The following is a description of a gene set: studied in species Homo sapiens Abnormal CNS myelination Human Gene Set: HP_ABNORMAL_CNS_MYELINATION An abnormality of myelination of nerves in the central nervous system., and this is the list of marker genes: CNOT3, TRNT1, ALG8, NDUFAF4, SDHB, ZNF335, SAMHD1, MMUT, GTF2H5, POLR3B, KDM1A, MPLKIP, IBA57, NDUFS1, YIF1B, TRRAP (NCBI Gene Id 8295), MAT1A, NADK2, ZFX, D2HGDH, PIGO, ACTL6B (NCBI Gene Id 51412), SLC1A4, SUMF1, GFAP, ATP6V1A, POGZ, PGAP1, PPP2R1A, ATP1A3, EXOSC2, LSM11, INTS11, C2CD3, SLC35B2, MTTP, REPS1, DNM1L, UFC1, HCFC1 (NCBI Gene Id 8267), TMTC3, NDUFAF2, COX14, FOXG1, TRAPPC2L, TUFM, GLRX5, ADSL, KIF5A, LIPT1 (NCBI Gene Id 51601), H4C5, ASPA, NDUFV1, ALG2, PLEKHG2, RERE, FBXL4, DOHH, KCNN2, FBXO28, NDUFA6, DHX37, FAR1, PRUNE1 (NCBI Gene Id 91961), IFIH1, AARS1, STXBP1, EPRS1, ITPA, PEX7, DDX6 (DEAD-box helicase 6), TRMT5, GRIK2, WARS1, PIGU, MADD, RNF13 (NCBI Gene Id 11342), ALDH5A1, GET4, PPP1R15B, GEMIN4, COPB2, ALDH7A1, MED17, GLUL, FA2H, TPR, VPS33A, SPTAN1, NDUFS6, ALDH3A2, MED27, ATXN2, CYB5A, CLDN11, MMACHC, IFT56, LRPPRC, ADARB1 (adenosine deaminase RNA specific B1), LEMD2, KIDINS220, CARS1, DAG1, NEUROD2, SMPD4, YRDC, ALG14, FRMD5, ADAT3 (NCBI Gene Id 113179), HS2ST1, BRAT1, SIN3A, FOCAD, LMX1B, KARS1 (NCBI Gene Id 3735), PARS2, TUBB4A, PKDCC (NCBI Gene Id 91461), TNPO2, DDOST, HTRA1, ARF1, TMEM126B, PPP2CA, MLYCD (malonyl-CoA decarboxylase), RNF113A, CTC1 (NCBI Gene Id 80169), FUS, FCSK, PI4KA, GDAP1, PRKDC, ARX, EZH2, ISCA1, PEX16, PGAP3, PEX19, HMBS, RFX7, PHGDH, NUP188, YY1, FANCB, ATP9A, DYRK1A, ZNF148, ZMIZ1, PTEN, SOX10, ZC4H2, U2AF2, RAB11B, AP3D1, FZR1, ESAM, TRMT10A, SLC19A1 (NCBI Gene Id 6573), NKX6-2, SLC1A2, ISCA2, SCO2, PLAA, L2HGDH, SNIP1, RBM8A, TIMM22, KCNH5, ACY1, SLC35A2, GALC, NDUFS8, GOLGA2, TARS1, AHCY, PSAP, SMPD1, PIGS, FUCA1, FOXP1, AIFM1, PPFIBP1, NDUFAF3, RNASEH2A, QARS1, UBA5, FBP2, ACBD5, ALDH6A1, EXOSC1, BCAP31, CYP27A1, CHAMP1, GJC2, PDYN, PEX1, NRCAM, TIAM1, INSR, MCOLN1, ERCC6, NDUFA1, ARSA, TREM2, NARS2 (NCBI Gene Id 79731), SP110, INTU, WDR26, NDUFA11, GNB2, CDC40, NCDN, PPP3CA, SPG11, RNU4-2, COA8, GAA, PGM3, NDUFV2, PGAP2, COG3, GAN, GABRA2, RAB3GAP1, GTF2E2, PEX10, TGFB1, SLC25A12, TBCD, GNAO1, HSD17B4, YME1L1, NDUFS7, RNASET2, ASH1L, ZNF526, SPTLC1, ABCD1, ATP6AP2, EIF2B1, ERCC2, SLC2A1, NEDD4L, TMEM240, NARS1, TKFC, POLR1C, EXOSC5, PIBF1, SHANK3, COX6B1, DHX30, TAF2, ARNT2, TREX1, AFG2A, PLP1, HNRNPC (NCBI Gene Id 3183), CLCN3, RNASEH2B, TBC1D24 (TBC1 domain family member 24), EXOC2, ATP11A, CLCN7, CACNA1I, C2orf69 (NCBI Gene Id 205327), DPAGT1, PHACTR1, HLA-DQB1, NDUFB11, UPB1, MT-ND1, TMEM163, PURA, HSPD1, NDUFB9, DARS2, CDK19, SETD1A, PLPBP, NDUFB3, ADGRG1, ELOVL4, DARS1, MTHFS, EDNRB, RMND1, CLTC, GLYCTK, GPT2, ABAT, TEFM, PRF1 (NCBI Gene Id 5551), IDUA, PIGW, HEXB, WARS2, SMG9, SLC6A1, BOLA3, TMEM106B, RHOBTB2 (NCBI Gene Id 23221), ALS2, MT-ND2, NOTCH2NLC, ELOVL1, IER3IP1, UGDH, PRMT7, POLR3A, BMP4 (NCBI Gene Id 652), CUL3 (NCBI Gene Id 8452), TNR, HYCC1, AHDC1, BCS1L, EARS2, CTNNB1, POLR2A, GLS, CNTNAP1, CTSK, ADAR, NDUFAF5, FOXRED1, TXN2, NOP10, GABRG2, CYB5R3, NDUFS3, SLC16A2, TMEM147, EIF2AK2, SLC12A5, PNPT1, FRMPD4 (NCBI Gene Id 9758), TMEM63A, NACC1, RAP1GDS1, CLTCL1, KCNT1 (potassium sodium-activated channel subfamily T member 1), GTPBP3, CSF1R, RNU7-1, RARS1, SLC33A1, NGLY1, ACER3, NUP133, DALRD3, MT-ND3, NDUFAF8, NDUFAF1, MRPL39, C18orf32, AIMP1, PIGY, PYCR2, ERCC1, CHKA, GABRA5, NMNAT1, PIGV (phosphatidylinositol glycan anchor biosynthesis class V), BCAS3, ALG9, TRIM8, NUBPL, VPS11, LIPT2, ERCC8, PIGG, POLR1A, ARID1B (AT-rich interaction domain 1B), LIAS, ACOX1, NAE1, HLA-DRB1, SPTBN1, PIGL, SNORD118, NDUFS2, NDUFB10, TAF13, MORC2, PPIL1, RNASEH2C, PRPS1, PIGA, SIGMAR1, TIMMDC1, ERCC3, NIPBL, MDH2, GRM7, POU3F3, MPV17, HIKESHI, WWOX, ALG13, CLPB, PC, EXOC8, PEX13, NRROS, SHPK, KCNC2, FANCL, TRAPPC11, NDUFS4, RNF220, AIMP2, TAOK1, STAMBP